The following is a description of a gene set: from publication Wagner KW, Punnoose EA, Januario T, Lawrence DA, Pitti RM, Lancaster K, Lee D, von Goetz M, Yee SF, Totpal K, Huw L, Katta V, Cavet G, Hymowitz SG, Amler L, Ashkenazi A (PMID 17767167) Apo2L/TRAIL stimulates cancer cell death through the proapoptotic receptors DR4 and DR5, but the determinants of tumor susceptibility to this ligand are not fully defined. mRNA expression of the peptidyl O-glycosyltransferase GALNT14 correlated with Apo2L/TRAIL sensitivity in pancreatic carcinoma, non-small-cell lung carcinoma and melanoma cell lines, and up to 30% of samples from various human malignancies showed GALNT14 overexpression. RNA interference of GALNT14 reduced cellular Apo2L/TRAIL sensitivity, whereas overexpression increased responsiveness. Biochemical analysis of DR5 identified several ectodomain O-(N-acetyl galactosamine-galactose-sialic acid) structures. Sequence comparison predicted conserved extracellular DR4 and DR5 O-glycosylation sites; progressive mutation of the DR5 sites attenuated apoptotic signaling. O-glycosylation promoted ligand-stimulated clustering of DR4 and DR5, which mediated recruitment and activation of the apoptosis-initiating protease caspase-8. These results uncover a new link between death-receptor O-glycosylation and apoptotic signaling, providing potential predictive biomarkers for Apo2L/TRAIL-based cancer therapy. species: Homo sapiens Genes whose expression most significantly correlated with cancer cell line sensitivity to the proapoptotic ligand APO2. Human Gene Set: WAGNER_APO2_SENSITIVITY, and this is the list of marker genes: FUT6, POFUT1, GALNT11, GALNT2, FUT3, GALNT6, GALNT12, GALNT10, GALNT9, GALNT15, GALNT13, FUT11, FUT2, FUT4 (fucosyltransferase 4), GALNT1, FUT5, GALNT16, FUT8, FUT10, GALNT5, GALNTL5 (polypeptide N-acetylgalactosaminyltransferase like 5), FUT9, GALNT3, GALNT14 (polypeptide N-acetylgalactosaminyltransferase 14), FUT7, GALNT8 (NCBI Gene Id 51803)